Given this list of marker genes RARA, NR2F1, ZNF536, RXRB, MYT1L, RXRG, RXRA (retinoid X receptor alpha), here is a description of the gene set: Human Gene Set: GOMF_RETINOIC_ACID_RESPONSIVE_ELEMENT_BINDING species: Homo sapiens Binding to a retinoic acid-responsive element, a variable direct repeat of the sequence PuGGTCA spaced by five nucleotides (DR5) found in the promoters of retinoic acid-responsive genes, to which retinoic acid receptors bind.